Given this list of marker genes RPLP2, EEF2, RPL41 (ribosomal protein L41), RPS25, RPS27L (NCBI Gene Id 51065), RPL34, UBA52, RPL10A, RPS11, RPS14, RPS20, RPL10L, RPL29, EEF1D, RPS29, RPS6, RPLP0, RPL23A, RPS23, RPL24, RPS4X, RPL7A, RPL18, RPL36AL, RPS10, RPL26L1, RPS18, RPL12, RPL38, RPLP1, RPL7, RPL21 (ribosomal protein L21), RPL39L, RPL17, EEF1G, RPL32, RPS28, RPL3, RPL36, RPL35A, RPS4Y1, RPL15, RPL31, RPL39, RPL4, RPL22L1, RPS26, RPL27A, RPS2, FAU, RPL37A, RPS27, RPL19, RPS19, RPS12 (ribosomal protein S12), RPL13, RPS17, RPL35, RPS15A, RPL10, EEF1B2, RPS8, RPL23, RPS13 (NCBI Gene Id 6207), RPS3, RPL6, RPS7, RPL36A, RPS3A (NCBI Gene Id 6189), RPL14, RPS5, EEF1A2, EEF1A1, RPL22, RPS21, RPS4Y2, RPL27, RPL13A, RPL9, RPL11, RPSA, RPL8, RPS24, RPL3L, RPL37, RPL18A, RPL5, RPL28, RPS27A, RPS9, RPL30, RPS16, RPL26, RPS15, here is a description of the gene set: Eukaryotic Translation Elongation Human Gene Set: REACTOME_EUKARYOTIC_TRANSLATION_ELONGATION species: Homo sapiens